Given this list of marker genes Amfr, Sptbn1, Sod1, Msh2, Rad50, Pten, Krt18, Rassf1, Tsc1, Cul9 (NCBI Gene Id 78309), Fzr1, Apc, Bhmt, Plk3, Nr1h4 (nuclear receptor subfamily 1, group H, member 4), Plau, Sav1, Nsmce2, Hip1, Xpa (NCBI Gene Id 22590), Fah, Mir122, Tspan33, Fen1, Nudt1, Cers2, Cbx7, Kras, Brca1 (breast cancer 1, early onset), Acox2, Trim24, Mfsd1, Bub1, Pinx1, Fasl, Rcbtb2, Pex5, Fdxr (ferredoxin reductase), Trp53, Usp24, here is a description of the gene set: from publication Motenko H, Neuhauser SB, O'Keefe M, Richardson JE (PMID 26092688) species: Mus musculus Mouse genes annotated to increased liver tumor incidence (MP:0008019) retrieved from the Mouse Genome Informatics database via MouseMine Mouse Gene Set: MP_INCREASED_LIVER_TUMOR_INCIDENCE